Given this list of marker genes COQ7, TREM2, GLE1, COQ4 (coenzyme Q4), MATR3 (matrin 3), VCP, FUS, GALC, ANXA11, GLT8D1, DCTN1, UBQLN2, HNRNPA1, OPTN, PRPH, NEK1, VAPB, PFN1, PPARGC1A, BCAT2 (branched chain amino acid transaminase 2), ANG, UCHL1, ATXN2, ABCD1, CHMP2B, ALDH18A1, SQSTM1, NEFH, SOD1, DAO, CCNF, CHCHD10, UNC13A, PI4KA, CFAP410, PON1, FIG4, TAF15, TBK1, PON3, TARDBP, ERBB4, ERLIN1, REEP2, PON2, CHP1, here is a description of the gene set: A Hoffmann test is performed by flicking the fingernail of the long finger, from dorsal to volar, on each hand while the hand was supported by the examiner's hand. The test was done with the neck in the neutral position and then with the neck maximally forward flexed. Any flexion of the ipsilateral thumb and/or index finger was interpreted as a positive test. Human Gene Set: HP_HOFFMANN_SIGN studied in species Homo sapiens Hoffmann sign